The following is a description of a gene set: Human Gene Set: HOFT_PBMC_TICE_BCG_RBCG_AG85A_AG85B_AGE_18_40YO_CORRELATED_WITH_WHOLE_BLOOD_BACTERICIDAL_ACTIVITY_NEGATIVE from publication Hoft DF, Blazevic A, Selimovic A, Turan A, Tennant J, Abate G, Fulkerson J, Zak DE, Walker R, McClain B, Sadoff J, Scott J, Shepherd B, Ishmukhamedov J, Hokey DA, Dheenadhayalan V, Shankar S, Amon L, Navarro G, Podyminogin R, Aderem A, Barker L, Brennan M, Wallis RS, Gershon AA, Gershon MD, Steinberg S (PMID 27322481) BACKGROUND: We report a first-in-human trial evaluating safety and immunogenicity of a recombinant BCG, AERAS-422, over-expressing TB antigens Ag85A, Ag85B, and Rv3407 and expressing mutant perfringolysin. METHODS: This was a randomized, double-blind, dose-escalation trial in HIV-negative, healthy adult, BCG-naÃ¯ve volunteers, negative for prior exposure to Mtb, at one US clinical site. Volunteers were randomized 2:1 at each dose level to receive a single intradermal dose of AERAS-422 ( > 10(5)- < 10(6)CFU=low dose, â‰¥10(6)- < 10(7)CFU=high dose) or non-recombinant Tice BCG (1-8Ã—10(5)CFU). Randomization used an independently prepared randomly generated sequence of treatment assignments. The primary and secondary outcomes were safety and immunogenicity, respectively, assessed in all participants through 182days post-vaccination. ClinicalTrials.gov registration number: NCT01340820. FINDINGS: Between Nov 2010 and Aug 2011, 24 volunteers were enrolled (AERAS-422 high dose, n=8; AERAS-422 low dose, n=8; Tice BCG, n=8); all were included in the safety and immunogenicity analyses. All 24 subjects had at least one adverse event, primarily expected local reactions. High dose AERAS-422 vaccination induced Ag85A- and Ag85B-specific lymphoproliferative responses and marked anti-mycobacterial activity in a whole blood bactericidal activity culture assay (WBA), but was associated with varicella zoster virus (VZV) reactivation in two vaccinees. These volunteers displayed high BCG-specific IFN-Î³ responses pre- and post-vaccination possibly predisposing them to autocrine/paracrine negative regulation of immune control of latent VZV. A systems biology transcriptomal approach identified positive correlations between post-vaccination T cell expression modules and WBA, and negative correlations between post-vaccination monocyte expression modules and WBA. The expression of one key macrophage marker (F4/80) was constitutively elevated in the two volunteers with zoster. INTERPRETATION: The unexpected development of VZV in two of eight healthy adult vaccine recipients resulted in discontinuation of AERAS-422 vaccine development. Immunological and transcriptomal data identified correlations with the development of TB immunity and VZV that require further investigation. FUNDING: Aeras, FDA, Bill and Melinda Gates Foundation. Genes negatively correlated with whole blood bactericidal activity in peripheral blood mononuclear cell in adults (18-40) after exposure to Tice BCG/rBCG-Ag85A/Ag85B, time point 14D species: Homo sapiens, and this is the list of marker genes: FCRL6, PDGFD, NMUR1, RASGEF1A (RasGEF domain family member 1A), KLRF1, KLRB1, SIGLEC17P, MCTP2, ADCY9, AGAP1, SH2D1B, CD247 (NCBI Gene Id 919), SYNE1, SPIRE1, HOPX, KIR3DL1, FRMPD3, GZMH, PRF1, IL12RB2, NKG7, ATP2B4, TGFBR3, ELOVL6, CST7, GZMB, YPEL1, FGFBP2, IL2RB, SLC4A4, CACNA2D2 (calcium voltage-gated channel auxiliary subunit alpha2delta 2), IGFBP3, ARK2C, PRR5L, PHLDB2, NCR1, PRSS23, GNLY, CCL5, COLQ